The following is a description of a gene set: electronically inferred by orthology from the curated human pathway Reactome Pathway: Phosphorylation of Emi1 This event has been computationally inferred from an event that has been demonstrated in another species.<p>The inference is based on the homology mapping from PANTHER. Briefly, reactions for which all involved PhysicalEntities (in input, output and catalyst) have a mapped orthologue/paralogue (for complexes at least 75% of components must have a mapping) are inferred to the other species. part of: Regulation of APC/C activators between G1/S and early anaphase studied in species Mus musculus, and this is the list of marker genes: Ccnb1, Cdk1, Plk1, Fzr1